The following is a description of a gene set: Reactome Pathway: Peptide chain elongation part of: Eukaryotic Translation Elongation The mechanism of a peptide bond requires the movement of three protons. First the deprotonation of the ammonium ion generates a reactive amine, allowing a nucleophilic attack on the carbonyl group. This is followed by the loss of a proton from the reaction intermediate, only to be taken up by the oxygen on the leaving group (from the end of the amino acid chain bound to the tRNA in the P-site). The peptide bond formation results in the net loss of one water molecule, leaving a deacylated-tRNA in the P-site, and a nascent polypeptide chain one amino acid larger in the A-site.<br>For the purpose of illustration, the figures used in the section show one amino acid being added to a peptidyl-tRNA with a growing peptide chain.<br> studied in species Homo sapiens, and this is the list of marker genes: RPL4, RPLP2, RPS4X, RPL41, RPS6, RPL10L, RPL22L1, RPS15A, RPL39L (NCBI Gene Id 116832), 5S rRNA, RPL36, RPL8, RPS11, RPL6, RPL32, RPS14, RPL18, RPL26L1 (ribosomal protein L26 like 1), RPL29, RPL26, RPL7A, RPS27L (NCBI Gene Id 51065), RPL17, RPL36AL, RPL30, RPS4Y1, RPS8, EEF2, RPS26, 5.8S rRNA, RPS4Y2, RPS3A, RPL31, RPL5, RPS10, RPL10, RPL3L, RPL12, FAU, RPS15, RPS25, RPL18A, RPS2, RPL38, RPL14, RPL19, RPS18, RPS24, RPL3, RPS28 (NCBI Gene Id 6234), RPS17, RPS19, RPL11, RPL36A, RPL7, RPS21, RPL39, RPL37, RPL10A, RPL9, RPS9, RPL35A, RPS29, RPS27, RPS3, RPL21, RPSA, RPS13, RPS20, RPL15, 18S rRNA, EEF1A1, RPL37A, RPL24, RPL28 (NCBI Gene Id 6158), RPL23, UBA52, RPS23, 28S rRNA, RPL22, RPL35, RPL34, RPS7, RPL13, RPS12, RPL13A, RPL27A, RPS27A, RPLP0, RPL23A (NCBI Gene Id 6147), RPS16, RPS5, RPL27, RPLP1